The following is a description of a gene set: Human Gene Set: GOBP_AMINE_TRANSPORT The directed movement of amines, including polyamines, organic compounds containing one or more amino groups, into, out of or within a cell, or between cells, by means of some agent such as a transporter or pore. studied in species Homo sapiens, and this is the list of marker genes: CRH (NCBI Gene Id 1392), ADRA2B, DRD1, SLC18A1, SLC7A5, FLVCR1, KCNB1, PER2, DTNBP1, GRM2, NPY2R, SLC18A2, OXT, RHCG, ATP1A2, SLC38A3, DRD4, PRKG1, RAB3B, ACE2, OPRK1, STX1A, FGF20, GDNF, CHRNA3, AVPR1A, RGS2, LEP, FFAR3, KMO, CHRNA6, GABBR1, CHGA, PRKN, SLC44A2, GRM7, SDHD, SLC43A1, AVP, NPY5R, CHRNB2, RGS4, GHSR (growth hormone secretagogue receptor), SLC17A8, SLC22A2, SLC38A2, PSEN1, SYT11, STXBP1, AQP8, ADORA1, DRD3 (dopamine receptor D3), AQP9, TOR1A, NTSR1, SYT1, ITGB1, CLTRN, TACR2, ADORA2A, PINK1 (NCBI Gene Id 65018), FLVCR2, SLC12A2, CHRNA4, ADRA2A, ADRA2C, TRH, HTR2A, P2RY1, CARTPT, SLC18A3, SLC43A2, SNCA, ARL6IP1, DRD2, SLC22A16, ARL6IP5, ABAT, RHAG, SNCG (synuclein gamma), TNF, KCNA2, SLC44A1, GRK2, SEPTIN2, RAB3GAP1, SYT4 (NCBI Gene Id 6860, synaptotagmin 4), ADORA3, CXCL12, P2RX7